Given this list of marker genes DAPK2, ZCRB1 (zinc finger CCHC-type and RNA binding motif containing 1), FES, FBXO10, ARRDC1, TTC21A, TAGAP, PTCH2, ZFYVE27, AATK, TRIM37, E2F1, TAOK2, FARP1, ERMARD, TRABD, LCMT1, IL15, RAD18, CENPT, COPS7B, OTUD3, PIH1D1, FOXM1, PROK2, RALYL, CSRP2, TMEM170A, TIGD3, FAT1, KLF2, DESI1, PAPPA, USP2, FSTL1, RAD54B, HAUS1, GPR63 (G protein-coupled receptor 63), ARHGEF26, ZGRF1, BICDL2, ADISSP, MOV10, EGR3, CDH11, SH2B1, SERF2, RASGEF1A, SUMO3, POU1F1, GINS2, ATXN7L1, CSTF1, MBD6, PPM1F, PKMYT1, HPCA, STMP1, TNKS1BP1, AP1M1, DKK4, PCYT2, SLC35B2, BLM, SRY, PTPRCAP, PLAGL1 (PLAG1 like zinc finger 1), ABCC5, TLE6, SNX11, IQGAP3, GMIP, WRAP53, DNAAF11, HELLS, BRIP1, VHL, ACTR1B, FGD3, GPRASP3, GDI1 (NCBI Gene Id 2664), RAF1, PSTPIP1, RUVBL2, PRG3, INTS7, SLC5A11, NANOS1, RAD51AP1, TP53I11, NFIC, SUDS3, PTGS2, MIIP, RFC2, FAM117A, DLGAP1, SEMA4F, TRIB1, APH1B, RAMP1, KLHL11, STX1A, DCAKD, MAPKAPK3, AGFG2, SLCO4A1, LDHC, PGD, MAG, PIAS4, CCHCR1, NCLN, DDIT3, AQP9, TRPM2, POLD1, MYO15B, SRSF2, APLNR, CCT7, MAST3, ZBTB40, CTR9, NDRG2, PIDD1, SELENOM, MND1, ADGRL4, DHRS11, JSRP1, TEX2 (testis expressed 2), RDM1, GSTM1, MVB12B, ITPRIP, UBASH3A, BARD1, RGL2, TFEB, LDHB, UBA7, NUP107, ZRANB1, TCF3, CD69, HPS1, TMUB1, ABI3BP, SMAD3, IGFBP4, SNAPC2, TMOD4, BTNL9 (butyrophilin like 9), TUBA3C, ZBTB17, LDB2, AGT, HDAC7, TNC, MMP13 (matrix metallopeptidase 13), HCK, DTNB (dystrobrevin beta), WBP2, NIBAN3, MASTL, CEP152, AFF2, ARHGAP4, LGALS4, CCND3, NT5E, PCNX1, ALOX15 (NCBI Gene Id 246), TUSC1, COPS8, EBF3, NOS1AP, TSSC4, METRN (NCBI Gene Id 79006), OIP5, LMNB2, MCM10, HEPH (NCBI Gene Id 9977), WDR90, MEF2C, TNF, EZH2 (NCBI Gene Id 392834), CEP192, TYMS, PTTG1, EXO1, CKS1B, LSM11, CUEDC1, VASN, MCM7, SCARA3, FDFT1, APPBP2, here is a description of the gene set: from publication Yamagata T, Benoist C, Mathis D (PMID 16623764) species: Homo sapiens Genes down-regulated in CD8A T cells versus B1 B lymphocytes. Three innate (B1-B, NKT, CD8aaT cells) and adaptive (B2-B, CD4T, CD8abT cells) cell-types were sorted by FACS. Three biological replicates for NKT, CD4T, CD8aaT, CD8abT cells and two biological replicates for B1 and B2 cells were generated and the expression profiles were determined using Affymetrix Mu74Av2 chip. Comparisons between the sample groups allow the identification of genes differentially expressed between the innate and adaptive cell-types. Human Gene Set: GSE3039_ALPHAALPHA_CD8_TCELL_VS_B1_BCELL_DN